Given this list of marker genes LMBR1, ARHGAP31, DLX6, TP63, BTRC, REV3L, EPS15L1, EOGT, SEM1, DLL4, IKBKG, DLX5, TBX3, FBXW4, RBPJ, DOCK6, PLXND1, NOTCH1, WNT10B, here is a description of the gene set: Absent hand studied in species Homo sapiens Human Gene Set: HP_ABSENT_HAND The total absence of the hand, with no bony elements distal to the radius or ulna.